Given this list of marker genes Fbxo5, E2f7, Senp2, Zpr1, E2f8, here is a description of the gene set: Regulated re-replication of DNA within a single cell cycle, resulting in an increased cell ploidy. An example of this process occurs in the synthesis of Drosophila salivary gland cell polytene chromosomes. species: Mus musculus Mouse Gene Set: GOBP_DNA_ENDOREDUPLICATION